Given this list of marker genes Cdkn1b, Tpx2, Xpa, Mapk14, Plk3, Srpx, Tnk1, Bub1b, Rassf5, Trp53, Braf, Mad1l1, Scrib, Fen1, Cdkn2c (NCBI Gene Id 97133), Becn1, Gpx7, Dok1, Men1, Kras, Nudt1, Prf1, Bin3, Prdx1, Gprc5a, Robo1, Hck, Dok3, Abraxas1, E2f1, Ppp2r1a, Tle1, Tgfbi, Dok2, Nbn, Fgf9, Sox2, Dna2, Xpc, Mcm4, Mad2l1, Pcbp4, Lmo7, Pten, Lzts1, Eif4e, Trim62, Hic1, Ifng, Prdm2, Nf2, Sptbn1, Trp73, Atad5, Eaf2, Pold1, Smg1, Dnai7, Rint1, Nf1, here is a description of the gene set: Mouse Gene Set: MP_INCREASED_LUNG_ADENOCARCINOMA_INCIDENCE studied in species Mus musculus Mouse genes annotated to increased lung adenocarcinoma incidence (MP:0002027) retrieved from the Mouse Genome Informatics database via MouseMine from publication Motenko H, Neuhauser SB, O'Keefe M, Richardson JE (PMID 26092688)